The following is a description of a gene set: part of: Translation of Structural Proteins This COVID-19 pathway has been created by a combination of computational inference from SARS-CoV-1 data (https://reactome.org/documentation/inferred-events) and manual curation, as described in the summation for the overall SARS-CoV-2 infection pathway.<br><br>Protein 3a is associated with protein M and is found in the virion, although its function in the structure seems non-essential. 3a is O-glycosylated and forms a homotetramer with porin function studied in species Homo sapiens Reactome Pathway: Maturation of protein 3a_9694719, and this is the list of marker genes: ST6GALNAC3, ST3GAL2, ST3GAL3, ST6GAL1, ST6GALNAC4, ST3GAL4, 3a, GALNT1, ST3GAL1, ST6GALNAC2 (ST6 N-acetylgalactosaminide alpha-2,6-sialyltransferase 2)